Given this list of marker genes DHX9 (DExH-box helicase 9), FAAP20, EIF2AK2, IKBKB, FANCA, TUBA1B, TUBB8, ILF3, ILF2, MAPT, PPP2R1B, HSPA1B, TP53, NCK1, SUMO1, PPP2R1A, CDK1, TUBB2A (NCBI Gene Id 92919), FANCC, DUS2, STAT1, TUBA1C, NPM1, HSPA1L, TARBP2, CENPS, TUBA1A, TUBA4B, TRIM25, CENPX, HSPA8, PPP2CB, TUBA8, MAVS, UBE2L6, UBE2I, ARIH1, TUBB2B, FANCF, TUBB3, TUBA3D, PRKRA, TUBB4B, PPP2CA, STAT3, ISG15, TUBB6, ADAR, SPHK1, TUBAL3, FANCB, SNCA (NCBI Gene Id 6622), MAP2K6, FANCM, HSPA1A (NCBI Gene Id 3303), FANCL, HSPA2, EIF2S3, TUBA3C, EIF2S1, TUBA3E, FANCG, TUBB4A, CHUK, PTPN2 (NCBI Gene Id 5771), EIF2S2, TUBB1, FAAP24, FAAP100, TUBB8B, TUBA4A, PPP2R5A, DNAJC3, FANCE, HERC5, IKBKG, here is a description of the gene set: PKR-mediated signaling Human Gene Set: REACTOME_PKR_MEDIATED_SIGNALING studied in species Homo sapiens